The following is a description of a gene set: studied in species Mus musculus Mouse Gene Set: GOBP_SECONDARY_PALATE_DEVELOPMENT The biological process whose specific outcome is the progression of the secondary palate from an initial condition to its mature state. This process begins with the formation of the structure and ends with the mature structure. The secondary palate is the part of the palate formed from the fusion of the two palatine shelves, extensions of the maxillary prominences., and this is the list of marker genes: Fzd1, Tgfbr2, Tbx1, Wnt11, Tgfb2, Wnt7a, Foxe1, Tgfb3, Sox11, Col11a2, Itgb6, Tshz1 (NCBI Gene Id 70498), Smad2, Smad4, Wnt5a, Chd7 (chromodomain helicase DNA binding protein 7), Wnt8a, Lrrc32, Tgfbr3, Lef1, Dlg1, Wnt3a, Fzd2, Gabrb3, Mmp25, Itgb8, Jag2